The following is a description of a gene set: studied in species Mus musculus The transfer of electrons through a series of electron donors and acceptors, generating energy that is ultimately used for synthesis of ATP. Mouse Gene Set: GOBP_ATP_SYNTHESIS_COUPLED_ELECTRON_TRANSPORT, and this is the list of marker genes: Park7, Uqcr10, Ndufv3, Mir451a (NCBI Gene Id 723870), Ndufs6, Cox5a, Cox8c, Cox7b, Ndufs1, Coq7, Cox8b, Cox6a2, Cox4i1, Sdhaf2, Uqcc3, Ndufa10, Iscu, Chchd2, Uqcrq, Ccnb1-ps, Uqcr11, Cox7a1, mt-Co3, mt-Cytb, Mir451b, Dld, Uqcrc2, mt-Co2, Ndufc2, Cox4i2, Ndufs8, Coq9, Tafazzin, Ndufa8, Cox5b, Ndufaf1, Cyct, Pink1, Dguok, Cox7a2, Mtch2, Sdhd, Ndufv2, mt-Nd1, mt-Nd3, Ndufv1, Ccnb1, Ndufa12, Ndufb6, mt-Nd2, Ndufb9, Afg1l, Cox7c, Uqcrfs1, Uqcrb, mt-Nd4, Dnajc15, Cox6a1, Sdha, Ndufs7, Sdhb, Sdhc, Ndufs2, Coa6, mt-Nd6, Uqcrh (NCBI Gene Id 78331), Bdnf (NCBI Gene Id 12064), Snca, Cdk1, Cox7a2l, Ndufb8, Ndufa7 (NCBI Gene Id 66416), mt-Nd5, Cox8a, Ndufs3, Cycs (NCBI Gene Id 13063), Cyc1, Ndufa11, mt-Nd4l, Chchd2-ps, Cox7b2, Uqcrc1 (ubiquinol-cytochrome c reductase core protein 1), Bid